Given this list of marker genes Htr2c, Nr1h4, Enpp7 (NCBI Gene Id 404708), Pcx, Apoc2l, Fabp3, Spata18, Adgrf5, Htr2b, Prkcd, Capn2, Apoc2, Rab38, Erbb4, Acsl3, Htr2a, Chp1, here is a description of the gene set: studied in species Mus musculus Any process that activates or increases the frequency, rate or extent of phospholipid metabolic process. Mouse Gene Set: GOBP_POSITIVE_REGULATION_OF_PHOSPHOLIPID_METABOLIC_PROCESS